The following is a description of a gene set: species: Homo sapiens Human Gene Set: NAKAYA_PBMC_FLUARIX_FLUVIRIN_AGE_18_50YO_3DY_UP from publication Nakaya HI, Wrammert J, Lee EK, Racioppi L, Marie-Kunze S, Haining WN, Means AR, Kasturi SP, Khan N, Li GM, McCausland M, Kanchan V, Kokko KE, Li S, Elbein R, Mehta AK, Aderem A, Subbarao K, Ahmed R, Pulendran B (PMID 21743478) Genes up-regulated in peripheral blood mononuclear cell 3d vs 0d in adults (18-50) after exposure to Fluarix/Fluvirin, time point 3D. Comment: Supplementary Table 1a: All the differentially expressed genes identified in PBMCs of TIV vaccinees. Here we have used a systems biology approach to study innate and adaptive responses to vaccination against influenza in humans during three consecutive influenza seasons. We studied healthy adults vaccinated with trivalent inactivated influenza vaccine (TIV) or live attenuated influenza vaccine (LAIV). TIV induced higher antibody titers and more plasmablasts than LAIV did. In subjects vaccinated with TIV, early molecular signatures correlated with and could be used to accurately predict later antibody titers in two independent trials. Notably, expression of the kinase CaMKIV at day 3 was inversely correlated with later antibody titers. Vaccination of CaMKIV-deficient mice with TIV induced enhanced antigen-specific antibody titers, which demonstrated an unappreciated role for CaMKIV in the regulation of antibody responses. Thus, systems approaches can be used to predict immunogenicity and provide new mechanistic insights about vaccines., and this is the list of marker genes: MRPL51, CDK2AP1, MLX, CRIPT, TMCO3, COPS7A, FUCA2, IER3IP1, TM2D1, EXOSC1 (exosome component 1), DCAF10, PCMT1, DBNL, COG5, LRRC8D, MRPL30, THYN1 (NCBI Gene Id 29087), ASXL2, SDHC, NUDT22, MIEN1, MRPS12, SNX11, HVCN1, FBP1, RASSF4, CUX1, RRAGA, RAB1B, RCAN1, SORT1, NACC2, TARS1, DHRS4L2, CORO1A, UBN2, VIPAS39, DRG1, CORO1C, ORMDL2, ALDH3A2, FEM1B, ICMT, NEDD8, RAB27A, STARD3NL, DBI, TMEM185A, FUCA1, MGST3, KDELR2 (NCBI Gene Id 11014), WASHC4, GRSF1, IPO8, BID, GZMA, VTI1B (vesicle transport through interaction with t-SNAREs 1B), TXN2, FEZ2, G3BP1, SPON2, CLTA (clathrin light chain A), CALHM2 (NCBI Gene Id 51063), TRIM27 (NCBI Gene Id 5987), DHRS4, FBXW11, NXT2, MOSPD2, FMNL2, TOR1A, TMED9, DECR1, MPDU1, CYRIA, SH2D1B (NCBI Gene Id 117157), MAPKAPK3, OSBPL11, C14orf119, PFDN6, TK2, ELP3, SGPL1, SPTLC2, TRIQK, TMEM107, TBXAS1, RAP2A, FKBP1A, HIGD1A, PIGF, CYFIP1, SLC25A20, HMGN4, PARP4, STX6, COQ2, NLRC4, DISC1, HCST, SDAD1, IPO7, DPP8, SERPINB6, CALHM6, LAIR1, STOM, LST1, CWC27, CD300C, SLC43A3, C21orf91, ARF5, TMEM218, LINC01560, SUCLG1, UBE4A, CEP15, FIG4, PRCP, ACER3, TMT1A, GNGT2, TFCP2, CBL, ARF6, DNAJC16, SLC35A5, MIB1, PIN4, WIPI2, MRPL35 (NCBI Gene Id 64980), CD53, LYAR, EDEM3, PSMD4, USB1, C1orf162, SELPLG, HYPK, CST7 (NCBI Gene Id 8530), GOLPH3, HENMT1, GIMAP4, FASTKD3, PPP1CA, SLC25A11, NDUFA8, ARMC1, SCAMP1, OXR1, TIMM8B, AIF1, AP1S2, MED13, RALA, PIK3AP1 (NCBI Gene Id 118788), PNPO, PAPSS1, MILR1, ZCCHC17, SCOC, CKLF, ZEB2, PPA2, CAT, MESD, LPCAT3, ZSWIM6, AP2A1, MRPL18, UCHL3, MYCBP, FGD4, QKI, MYCL, ARRB1, CPSF2, GON7, CCT3, HSBP1, AIDA, TTC9C, TMCO1, KDM1B, COPS5, FNIP2, DOK2, GPBAR1, APOBEC3G, FAR1 (fatty acyl-CoA reductase 1), TMX3 (NCBI Gene Id 54495), MGST2, VAMP8, PSMD14, TASOR, BTBD7, LIPA, CYB561D2 (cytochrome b561 family member D2), DPYSL2, BLVRA, TMBIM4, POP4, NSL1, MS4A6A, PRAM1, TIPRL, YIPF1, YIPF6, DICER1, TRPS1, FLI1, UBE2V2, SNX27 (NCBI Gene Id 81609), RRAS, PSMC2, CYB5A, SUPT4H1, ANXA4, APAF1, EPB41L3, ZNF641, DNAJB6, VPS72, GPALPP1, ZMYM6, CDKN1C, CCDC115, TPI1, PLRG1, MRM2, MGLL, RABGAP1L, TMX1, HIKESHI, SNAPC5, COX15, MTSS1, FZD1, PPP2CB, PECAM1, TMPO, TUBB (tubulin beta class I), PMVK, PPP3CB, CNTRL, AHCYL1, EEA1, AK2, ZMPSTE24, KRCC1, CHMP4A, ILK, PGM2, TXNDC9, SLX1A, CHST2, FAM32A, POLR1D, PTPRJ, PRSS23, ASH2L, ICAM2, RWDD2B, PSMB2, PRF1, VRK2, MPLKIP, AGFG1, OAZ2, MRPL15, BSG, WSB2, PBRM1, HTATIP2 (HIV-1 Tat interactive protein 2), HMOX2, RPS6KA1, ME2, MAPK1, VPS41 (NCBI Gene Id 27072), SULT1A3, SETD3, GLIPR1, FIBP, IFI16, GTF3C6, HSD17B4, ABRACL, TXNDC15, SLK (STE20 like kinase), MRPS6, CSRP1, POLR3K, ERMP1, MGAT2, NDUFB3, GIMAP6, PDE6D, SDHAF2, NDUFAF1, LAMTOR2, HADH, PPP1R7, MRPS11, HAUS1, VPS35, CSF1R, GTF2H5, IQGAP1, PUDP, CFAP298, TCAIM, ATP6V0E1, POU2F2, GIMAP1, SELENOW, REEP5, JAGN1, PAK1, GMPR2, LYPLA1, CTSA, RDH11, RNASE2, IL27RA, OSTM1, AGPS, ABI3, C3AR1, CLN5, ZNF146, AKAP10, SLC8A1, PPM1G, KIAA0930 (NCBI Gene Id 50610), TMEM19, ACTR1A, TSNAX, AFTPH, GPKOW, TTF1, SLX1B, TRAPPC3, DNAJC7, ADGRE2, HPS5, BICD2, MRPL19, TMEM87B, EXOC5, TADA3, MARCHF1, COMMD8, IGFBP7 (NCBI Gene Id 3490), COQ5, SNX19, CLEC12A, PPP3CA, PURA, C15orf39, VPS45, TNFAIP8L2, RNASE6, SYK, DPY30, STX8, TRAC, UQCC3, SLC26A2, DDRGK1, AP3B1, IL17RA (NCBI Gene Id 23765), C2orf74, MEA1, LYST, NFATC3, TPST2, METTL5, PLPBP, FAHD1, BANF1, ATP2B4 (NCBI Gene Id 54594), CCDC90B, TMX2, TAPBPL, NDUFV3, AP2S1, ARNT, RPE, TAOK1, TOMM5, ECHDC1, HPF1, CCR5, LFNG, GBA1, ANKRD17, LACC1, HPS3, CDK4, MTCH2 (NCBI Gene Id 23788), PGLS, KCNE3, SULT1A4, GTF2H1, SEC62, KCNK3, LILRB2, CAP1 (NCBI Gene Id 10487), RHOC, RAB10, NBR1, SLC25A12, DLEC1, AKR7A2, MRPL36, NDUFB5, RCBTB2, PSMD1, OGFOD1, INTS6, RPS27L, IRAK3, NAA38, KMT5B, COA6, SHQ1, VDAC1, CD86, HMOX1, BARD1, LINC00324, UBE2L3, MAP3K7, GLB1, AKR1C3, TINF2, CASP1, KLRD1, MCTS1, ADA, CD36, ATP6V1C1, ZMAT3, MRPS14, PDHB, GAPT, TLR8, SEC22B (SEC22 homolog B, vesicle trafficking protein), NAGA, ABCD3 (ATP binding cassette subfamily D member 3), DYNLL1, SLC25A46, SEC23IP, COA3, IDH1, GIMAP2, DENND10, PDGFD, NDUFS1, PRDX1, KIF3B, MICU1, MPV17, FKBP15, ADAP2, SCYL2, GSAP (NCBI Gene Id 54103), ADGRE1, PDCD6IP, RMDN1, CLTC (clathrin heavy chain), PTGDR, ARF3, CHURC1, OSTF1, ZCRB1, GALNT1, CYB5B, ARFIP1, CX3CR1, ARV1 (ARV1 homolog, fatty acid homeostasis modulator), GPN3, ANAPC13, TBC1D1, ADGRG1, SCAF11, MTIF2, HNMT, CLCN3, CD300LF, SIGLEC7, RAB8A, EIF2B3, SERF2, PLAC8, PDZD11, TIMP1, GNPDA1, MS4A4A, PDHX, UBE2K, KLRF1, MS4A7 (membrane spanning 4-domains A7), GALC, ZNF25 (NCBI Gene Id 7573), SFT2D1, PDLIM5, TRAPPC1, TLR5, PCNA, LRIF1, ELAVL1, RNF14 (NCBI Gene Id 9604), B3GALT6, GATD3, CLIC3, MTMR11, CD160, NAAA, CALML4 (calmodulin like 4), MRPS18C, UQCC2, SPTSSA, TXNDC17, SLIRP, PPID, CCDC126, SASH1, HAVCR2, ANKMY2, SNAPIN, ING4, OPN3 (NCBI Gene Id 23596), CCR2, UBR7, AHSA1, ALDH9A1 (aldehyde dehydrogenase 9 family member A1), PTER, LY86 (NCBI Gene Id 9450), CNIH4, ACP3, CTSL, CLEC12B, OCA2, CAPN1, ATP6V1B2, IL10RB, RPA2, CREBL2, STYXL1, TCF7L2, CD244, SNX5, CHCHD1, UBE2E2, CYSLTR1, CSTB, UQCR10, EIF2S1, RNF20, PSMD10, ARSD, PSEN1, C11orf71, M6PR, TMEM126B, MTF2, MRPS28, GIMAP8, SLC7A7 (solute carrier family 7 member 7), VKORC1L1, COPZ1, CERT1, DAPK1, SGO2, CTBP2, DNAJC8, ARL5A, APOBEC3F, BCAT1, ATP6V1D, HDHD2, CYBRD1, NDUFB7, ARHGAP18, POLR1H, G6PC3, ECH1, LY96, MAT2B (methionine adenosyltransferase 2 non-catalytic beta subunit), AP2B1, TMEM167A, FCER1G, CBX1, NEK7, MRPL20, GART, CCT5 (NCBI Gene Id 22948, chaperonin containing TCP1 subunit 5), TRIM69, INIP, BMPR2, CTSC, VPS26C, CD300A, MERTK, ACAA2, LSM10, IDE, MKKS, GNS, STAM2, SP1, STX7, B3GALT4, EFCAB14, YIF1B, DYNC1I2, LTA4H, MTMR12, RNF5, SKA2, RAB7A, CTNND1, ESPN, GLRX